Given this list of marker genes DNAJA2, FBXL16, NCOR1, PDE4D (phosphodiesterase 4D), SETBP1, PRPF38A, MAGI1, MBTD1, LDB1, EDA2R (NCBI Gene Id 60401), LRRC32, FBXW10B, POLR2D, PCDH11X, PLK2, ADCY1, PPME1, PPM1H, ZFAND5, LNX2, SRY, SBF1, TXLNG, C19orf84, PPM1M, STK40, EEF1AKMT4, FXYD6, SDC3, PLEKHA8, RAB22A, JADE1, HAGH, MORF4L2, MMAB, PTPRF, MSANTD3, RGSL1, LARP1, PCBP3, GRAP2, GIPC3, PLXDC2, PHF11, TAB2, NKAIN2, ZNF410, USP9X, ZNF609, here is a description of the gene set: studied in species Homo sapiens Genes predicted to be targets of miRBase v22 microRNA hsa-miR-4741 in miRDB v6.0 with MirTarget v4 prediction scores > 80 (high confidence targets). Human Gene Set: MIR4741 from publication Chen Y, Wang X (PMID 31504780)